Given this list of marker genes EIF2B1 (NCBI Gene Id 1967), SRP9, IRF9, RBBP4, IL15RA, HLA-C, PLSCR1, XRCC6, BST2, SKP1 (NCBI Gene Id 6500), STAT1, SDCBP, FAS, IFI30, HLA-E, TEAD4, GBP1, TRIM21, SEM1, IFITM1, ZFP36L2, IFI16, PSME1, IFIT2, COL16A1, CSRP3, EPS15, NAP1L1, RHOC, TAP1, HADHB, PPP3CA, VAT1, BTG1, B2M, ADAR, C1S, VEGFC, BAK1, PARP1, NMI, ELK4, PMAIP1, IL6, PSMB8, PPP5C, ICAM1, IFI35, PSMB9, FOSL1 (FOS like 1, AP-1 transcription factor subunit), PSMB10, IRF1, SRSF2, HLA-A, SP110, PML, MAP3K10, CASP8, BAG1, SF3A1, ATP6V0B, IFIT3, PRAME, CYCS, HADH, TRIM26, PLOD2 (procollagen-lysine,2-oxoglutarate 5-dioxygenase 2), ISG15, CEBPD, BBC3, SSBP1, here is a description of the gene set: The pleiotropic activities of interferons (IFNs) are mediated primarily through the transcriptional regulation of many downstream effector genes. The mRNA profiles from IFN-alpha, -beta, or -gamma treatments of the human fibrosarcoma cell line, HT1080, were determined by using oligonucleotide arrays with probe sets corresponding to more than 6,800 human genes. Among these were transcripts for known IFN-stimulated genes (ISGs), the expression of which were consistent with previous studies in which the particular ISG was characterized as responsive to either Type I (alpha, beta) or Type II (gamma) IFNs, or both. Importantly, many novel IFN-stimulated genes were identified that were diverse in their known biological functions. For instance, several novel ISGs were identified that are implicated in apoptosis (including RAP46/Bag-1, phospholipid scramblase, and hypoxia inducible factor-1alpha). Furthermore, several IFN-repressed genes also were identified. These results demonstrate the usefulness of oligonucleotide arrays in monitoring mammalian gene expression on a broad and unprecedented scale. In particular, these findings provide insights into the basic mechanisms of IFN actions and ultimately may contribute to better therapeutic uses for IFNs. from publication Der SD, Zhou A, Williams BR, Silverman RH (PMID 9861020) Genes up-regulated in HT1080 (fibrosarcoma) cells by treatment with interferon gamma for 6 h. Human Gene Set: DER_IFN_GAMMA_RESPONSE_UP species: Homo sapiens